Given this list of marker genes LAIR1, DHDH, RPGRIP1, KCNK5, PRKAR2B, JRK, BCO2, SLC26A9, FBXO27, IL6ST-DT (NCBI Gene Id 441072), MPV17L, AGR2, RAB26, CFAP144P1 (NCBI Gene Id 392661), KLHL30, SLC6A16, GHR, ID2-AS1, APOB, TDRD6, A1BG, RASSF4, MUCL1, NUDT8, GRK4, STOX1, GSTA7P, MIR3936HG, IQCN, FZD4-DT, PLIN4, LGALS2, PSG8, OCLNP1, GASK1A, MARCO, PDHA1, LINC00482, LINC01554, C5orf46, PNLIPRP3, FRAT1, HCG9, TACC2, S100P, ACACB, FGD3, USP43, PAIP2B, JAKMIP2, RNF148, GPC6, BTNL9, SLIT2, DENND3, ABCD2, TMEM8B, SP2-AS1, SOD2-OT1, FGD4, ARHGAP20, ITGA8, DIO2, PTPRQ (protein tyrosine phosphatase receptor type Q), PRODH, RALGPS1, GCH1, SPTB, PDE8B, VSIG1, BEST2, RASGRP2, PLAAT2, EPHA10, NR3C2, DHRS9, DOK7, ZBED3, ANKRD30A, TMEM116, FA2H, TRMT9B, ZBED3-AS1, LY6D, MBP (NCBI Gene Id 4155), SPINK5, LINC02405, KRT4, CYP7B1, MRC1, ZFP2, ADARB2, here is a description of the gene set: Human Gene Set: MEBARKI_HCC_PROGENITOR_WNT_DN Methods: Liver progenitor cells were incubated in a WNT-enriched microenvironment for 72hrs (200 ng/ml mouse recombinant purified Wnt3A from R&D Systems). Gene pathways dependent on downstream _-catenin were studied by _-catenin knockdown with specific siRNA. Gene pathways blocked by extracellular SFRP-like Wnt inhibitors were studied by co-incubating cells with recombinant purified FZD8_CRD (300 ng/ml, from R&D Systems). Independent culture experiments performed in triplicate include untreated cells or cells incubated with scrambled siRNA or with _-catenin-specific siRNA or with FZD8_CRD, alone or in combination with Wnt3A. Transcriptome of human HepaRG hepatocellular carcinoma liver progenitors in responses to a WNT3A-enriched microenvironment and dissection of pathways dependent on _-catenin and/or blocked by the SFRP-like Wnt inhibitor FZD8_CRD. studied in species Homo sapiens from publication Mebarki S, Désert R, Sulpice L, Sicard M, Desille M, Canal F, Dubois-Pot Schneider H, Bergeat D, Turlin B, Bellaud P, Lavergne E, Le Guével R, Corlu A, Perret C, Coulouarn C, Clément B, Musso O (PMID 27191501)